The following is a description of a gene set: Multiple myeloma (MM) is the most common form of plasma cell dyscrasia, characterized by a marked heterogeneity of genetic lesions and clinical course. It may develop from a premalignant condition (monoclonal gammopathy of undetermined significance, MGUS) or progress from intramedullary to extramedullary forms (plasma cell leukemia, PCL). To provide insights into the molecular characterization of plasma cell dyscrasias and to investigate the contribution of specific genetic lesions to the biological and clinical heterogeneity of MM, we analysed the gene expression profiles of plasma cells isolated from seven MGUS, 39 MM and six PCL patients by means of DNA microarrays. MMs resulted highly heterogeneous at transcriptional level, whereas the differential expression of genes mainly involved in DNA metabolism and proliferation distinguished MGUS from PCLs and the majority of MM cases. The clustering of MM patients was mainly driven by the presence of the most recurrent translocations involving the immunoglobulin heavy-chain locus. Distinct gene expression patterns have been found to be associated with different lesions: the overexpression of CCND2 and genes involved in cell adhesion pathways was observed in cases with deregulated MAF and MAFB, whereas genes upregulated in cases with the t(4;14) showed apoptosis-related functions. The peculiar finding in patients with the t(11;14) was the downregulation of the alpha-subunit of the IL-6 receptor. In addition, we identified a set of cancer germline antigens specifically expressed in a subgroup of MM patients characterized by an aggressive clinical evolution, a finding that could have implications for patient classification and immunotherapy. species: Homo sapiens from publication Mattioli M, Agnelli L, Fabris S, Baldini L, Morabito F, Bicciato S, Verdelli D, Intini D, Nobili L, Cro L, Pruneri G, Callea V, Stelitano C, Maiolo AT, Lombardi L, Neri A (PMID 15735737) Human Gene Set: MATTIOLI_MULTIPLE_MYELOMA_SUBGROUPS Genes differentially expressed in multiple myeloma (MM) patients: comparison of MGUS-like vs PCL-like samples; MGUS=monoclonal gammopathy of undetermined significance, PCL=plasma cell leukemia., and this is the list of marker genes: JPT2, GAGE1, HSD17B4, RUVBL1, SSX1, RRM2, CAD, DYNLL1, SMARCA4, MAGEA3, MAGEA12, GABARAPL1, FGF13, KLF9, NR1D1, SSX2, TTC3